The following is a description of a gene set: Any process that modulates the frequency, rate or extent of membrane depolarization during a cardiac muscle cell action potential. Human Gene Set: GOBP_REGULATION_OF_MEMBRANE_DEPOLARIZATION_DURING_CARDIAC_MUSCLE_CELL_ACTION_POTENTIAL species: Homo sapiens, and this is the list of marker genes: CAV3, MIR208A, RANGRF, SLMAP, GJA5 (gap junction protein alpha 5), ANK3